The following is a description of a gene set: from publication Luckey CJ, Bhattacharya D, Goldrath AW, Weissman IL, Benoist C, Mathis D (PMID 16492737) species: Homo sapiens Human Gene Set: GSE4142_GC_BCELL_VS_MEMORY_BCELL_DN Genes down-regulated in B lymphocytes: germinal center versus memory. In order to better understand the factors that regulate B cell differentiation upon exposure to antigen, we compares global gene expression profiles from naive B cells with antigen-specific plasma, germinal center, and memory B cells after immunization with the T-dependent antigen, NP-CGG. The memory B cell-enriched transcripts were then compared with memory T cell-enriched and hematopoietic stem cell-enriched transcripts in order to generate a transcriptional profile of self-renewal within the hematopoietic system., and this is the list of marker genes: KCNAB3, TMEM35B, FKBPL, KRT10, STN1, STX6, AMPD3, REC8, RAPGEF2, PHAX, SBK1, NCK1, NAGK, TFAM, UPF3B, PRPH (NCBI Gene Id 5630), COMMD6, MUC5B, IDH2, ATP6V1H, GPR151, ACVR2A, CCDC28B, ZWINT, NOXO1, CENPB, PIBF1, FBRSL1, TMEM82, UGGT2, QNG1, ANGPTL7, AURKB, VRK1, TMCO1 (NCBI Gene Id 54499), PPP2R3C, RDH14, PRPF38A, CIRBP, BSN, B3GAT2, APOOL, TMED10, GDAP2, TCEAL9, GINS4, RCOR3, SLC27A2, ETFDH, PLCH1, RIC8B, BCL7B, ZFYVE27, METTL13, MLANA, APBB1IP, USP20 (NCBI Gene Id 10868), MRS2, BAHD1, MEST, SLC22A17, FAM53C, OARD1, VPS33A, OIP5, TBC1D16, MOS, LRRC8D, ALOX15B, HIVEP2, TMEM179B, ICOSLG, ZNF827, SLC36A1 (solute carrier family 36 member 1), CDK19, RAD52, FAM98C, DAPP1, HIPK3, TMEM127, RHBDF1, CCN3, PIGL, NXPE3, ADGRA3, CSNK2B, CD34, MEAK7, TMLHE, NCBP3, MRNIP, AMZ2, ZNF14, PCDH7, PRXL2B, SDHC, PPP3R2, OXA1L, ZFAND1, ATG101, SMARCE1 (NCBI Gene Id 6605), CENPH, TMEM121, ZNF821, TCEANC2, ACOT8, COX8A, PTS, PFDN5, MIS12, TULP2 (NCBI Gene Id 7288), RNGTT, TNFAIP8, SERINC5, ANKRD12, PSD3, TNFSF14, SMYD3, ZNF408, AGXT2 (NCBI Gene Id 64902), FBXL19, FLT3LG, ATL3, SMIM19, BIRC5, ZNF22, MTMR1, KCTD18, TPP1, TADA1, GLUL, TYW3, SMARCA2, CST6, TK2, HNRNPM, TNFSF10, COQ10A, CHD9, RUFY2, CAB39L, ZMYND19, MINDY2, MEIS3, SLC41A1, RALGPS2, LEMD1, CD81, GNPTG, MYNN, COL6A1, DSTYK, ASAP2 (NCBI Gene Id 8853), CLK4, CA1, NUF2, CSNK1G1, KIN, VSIG10, TMPRSS3, MYOM3, B3GALT6, PRAMEF8, SPICE1, GPR108 (NCBI Gene Id 56927), SDHAF2, INMT, ACBD4, BDH1, IL1RAP, PPFIA3, ZFYVE1, PARP6, MTARC2, MS4A18, CLN3, PFN2, HACL1, DTNBP1, OAZ2, MYL11, ZDHHC17, ATAD2, TSPAN5, CFAP68, UNC5CL, HSPA14, PHF20L1, TRAK1, KCTD9, ZFP28 (ZFP28 zinc finger protein), ATP6V1F, UGDH, E4F1, PCP2, LFNG, ZNF688, RPS3, RGS10, MAP3K21